Given this list of marker genes MADD, TRHR, POU1F1, TSHR, SECISBP2, THRB, NKX2-5, here is a description of the gene set: Human Gene Set: HP_ABNORMAL_CIRCULATING_FREE_T3_CONCENTRATION Abnormal circulating free T3 concentration A deviation from the normal concentration of free triiodothyronine (T3) in the blood circulation. A proportion of T3 is bound to plasma proteins in the blood, including mainly thyroxine binding globulin, transthyretin, and albumin. T3 that is not bound to a protein is referred to as free T3. studied in species Homo sapiens